Given this list of marker genes UCP3, IRF6 (NCBI Gene Id 7452), FRZB (frizzled related protein), SLCO1B1, HTR2A, FLRT3, TYMS, FKBP5, BMP4, PPARG (NCBI Gene Id 5468), NOD2, ATP1B1, CLCNKA, BAX, SNRPN, TP53, GJB6, ADH5 (alcohol dehydrogenase 5 (class III), chi polypeptide), POMC, A2ML1, ADRB3, HLA-DQA1, ADD1, TAS2R16, NLGN4X, HLA-G, GNB3, SERPINH1, GABRA2, DYNC2H1 (NCBI Gene Id 79659), NOS3, F2, SMCHD1, NLRP1, HLA-DQB1, TAL1, ENPP1, MUC7, APOL1, ADH1C, NBN, GJB3, GHRL, SCGB3A2, RGS5, GDF3, IL6, ALOX5, NR0B2, STOX1, CCL11, PRKCH, CST3, ADH1B, GDF6, F5, HLA-C, TAL2, CLCNKB, ALOX5AP, HLA-B, IL13, BRCA1, SLITRK1, SLCO1B3, AGTR1, BCR, PAX4, CYP3A5, CFH, TPH2, SCN5A, DNMT3B, TNF, ECE1, NUP214, LRIF1, AGRP (NCBI Gene Id 181), CARTPT, PTGIS, ABCG8, GNB1, COL2A1, HNMT, FLT3, HTRA1, SDC3, GJB2 (gap junction protein beta 2), NEK1, HLA-DRB1, here is a description of the gene set: species: Homo sapiens Human Gene Set: HP_NON_MENDELIAN_INHERITANCE A mode of inheritance that depends on genetic determinants in more than one gene. Non-Mendelian inheritance